Given this list of marker genes Pparg, Acadl, Rgn, Pdk3 (NCBI Gene Id 67624), Slc22a13, Nucb2, C1qtnf2, Apoc2l (NCBI Gene Id 105886299), Ppara, Sirt1, Kat2b, Scap, Mtln, Wdtc1, Mlxipl, Nr1h3, Ppargc1a, Fmo2, Erlin2, Insig1, Mfsd2a, Akt2, Trib3, Ins2, Fabp3, Mlycd, Fabp1, Pla2g3, Abcd2, Brca1, Gk, Pdk4, Avpr1a, Ankrd26, Apoa5, Adipoq, Il1b, Dcaf5, Tysnd1 (trypsin domain containing 1), Cd74, Mir214, Dbi, Eif2ak3, Nfe2l1, Trex1, Abcd1, Appl2, Nr1h2, Cnr1, Prkag2, Apoc3, Gip, Sirt4, Akt1, Irs2, Dgat2, Apoc2, Cpt1a, Fabp5, Pdk2, Anxa1, Pank2 (pantothenate kinase 2), Sox9, Elovl5 (NCBI Gene Id 68801), Ghsr, Mtor, Acsl5, Apoc1, Klhl25, Abcb11, Twist1, Avp, Plin5, Acadvl, Fmo1, Pla2g4a, Ptgs2, Dgat1, Fmo4, Sirt2, Insig2, Gdf15, Ceacam1, Pibf1, Mapk9, Srebf1, Ceacam2, Tpk1, Cyp7a1, Obp2a, Bckdk, Cav1, Ubr4, Slc45a3, Lpgat1, Agt, Apoa4, Acsl4, Irs1, Etfbkmt, Erfe, Ins1, Snca, Hnf4a, Eif6, Pgk1, Erlin1, Pdk1, Acacb, Mir199a-2, Mid1ip1, Lonp2, Ncor1, Ppard, here is a description of the gene set: Mouse Gene Set: GOBP_REGULATION_OF_FATTY_ACID_METABOLIC_PROCESS species: Mus musculus Any process that modulates the frequency, rate or extent of the chemical reactions and pathways involving fatty acids.